Given this list of marker genes DPF2, TTK, SMARCA4, KAT5, SMC5, BUB1B, CDK5RAP2 (NCBI Gene Id 55755), BCL7B, ANAPC4, ARID1B, HORMAD1, HECW2, NCAPH, PHF10, ACTL6A (NCBI Gene Id 9178), RAD18, CSNK2A1 (NCBI Gene Id 1457), NSMCE2, MAPK15, ZWINT, ZNF207, SPC24, APC, ZWILCH, KNTC1 (kinetochore associated 1), ZW10, SMC4, SMARCD1, CHFR, BCL7C, USP44 (ubiquitin specific peptidase 44), NCAPH2, SMARCD2, TPR, CUL3, ARID2, CENPF, SMARCB1, BECN1, DPF1, FBXO5, SKA1, ANAPC2, CDC23, MAD2L1, KAT2B, SMARCE1, SMARCC2, SIRT2, XRCC3, NUF2, SPC25, DPF3, DUSP1, NCAPD3, MOS, ANAPC5, PPP2R2D, HNRNPU, UBE2C, CCNB1, TACC3, KIF2C, INCENP, PUM1, ACTB, SPDL1, BIRC5, MAD2L1BP, NEK6, TRIP13, PSMG2, PUM2, CDC20, ANAPC7, NCAPG2, RAD21, CDCA8, BUB1, KIF2B, NCAPG, MAGEA5P, PRP4K, DYNC1LI1, IK, CSNK2A2, RB1, ANAPC1, SMARCC1, ATM, ESPL1 (extra spindle pole bodies like 1, separase), HASPIN, PPP2R2A, MAD2L2, SMARCA2, DLGAP5, PBRM1, ACTL6B, NUMA1, SKA3, SMC2, AURKB, ARID1A, NCAPD2, BCL7A, CDC6, RMI2, SMARCD3, SIRT1, BRD7, C9orf78, CENPE, PLK1, BUB3, KLHL22, IHO1, ANAPC15, MAD1L1, ANAPC11, ENSG00000266560, MAP3K20, PRAP1, CDC16 (cell division cycle 16), CDC27, KNL1 (kinetochore scaffold 1), LCMT1, GEN1 (NCBI Gene Id 348654), TEX14, RIOK2, PLSCR1, NDC80, CDK1, SMC6, RCC2, here is a description of the gene set: Human Gene Set: GOBP_REGULATION_OF_CHROMOSOME_SEGREGATION studied in species Homo sapiens Any process that modulates the frequency, rate or extent of chromosome segregation, the process in which genetic material, in the form of chromosomes, is organized and then physically separated and apportioned to two or more sets.